Given this list of marker genes GPRC5C, NMI (N-myc and STAT interactor), RRM2, IRF7, NECTIN2, PTH1R, SLURP1, CXCL9, ESRRG, ACOT9, CFB, TYMS, EZH2, TRAFD1, SERPINE1, KCNJ14, CCR8 (NCBI Gene Id 1237), PCBP3 (NCBI Gene Id 54039), TNNT1, GABBR2, CCL3, BIRC5, ETV7, CBR1, AVPR1A, APOL1, IFITM3, H2AC18, JAK2 (Janus kinase 2), CHST8, CACNA1A, CD19, RBCK1, CCL7, IFNA6, GUCY1A2, CKS2, POLR3D, UBE2C, GRM7, LAMP5, HSPB1, BCL2L14, MT1X, TRIM21, ZBTB32, FAS, VCAM1, LYPD1, MMP25, SEPTIN4, MMP14, IL36A, HESX1, DYNLT1 (NCBI Gene Id 6993), IFIT3, APOL3, FST, GINS2, AURKB, CDC45, IL15, VAMP5, BATF3, AURKA, PLSCR1, MT2A, FHL2, IL9, XAF1, IFITM2, IDO1, CCL17, TRAF2, FA2H, INSM1, IGFALS, CHST3, PTGER3, NFE2L3, PARP11, RNASEL (NCBI Gene Id 6041), SRC, ADGRE5, VRK2, PLAC1, IGFBP1, MMP9, PML, IRF1, IFI6, NAMPT, OAS2, EIF2AK2, CLEC11A, RELB, IFI44L, IFIH1, KCNK5, AR, ESPL1, SP140, SIGLEC1, HSPBP1, GCH1, PSMB9, LIMK2, LAMP3, OAS1, MUC1, IFITM1, C1QA, SLCO4A1, FGL2, SLC6A12, SOCS2, PROCR, CD38 (CD38 molecule), MNDA, G0S2, IFI44, MX2, CXCL10, IL6, GMPR, SERPING1, FPR2, BMAL2, MYRF, GGT5, APBA1, LMO2, KIF13A, PARP3, SCNN1G, INHBA, ISG20, P2RY13, CLDN7, ZWINT, FSHB, CXCL1, LGALS3BP, PHLDA2, MAFF, TNFAIP6, AXL, KIFC3, CYP27B1, CXCL11, SIK1, SPHK1, MT1H, TK1, IFIT5, APOL6, MAP3K7CL, BST2, TFEC, ENPP2, APOBEC3B, ENTREP3, GDF11, FFAR2, H1-0, CCND1, TPX2, UBE2S, CCL13, USP18, MX1, EBI3, HERC5, GZMB, CCL2, C1S, ZBP1, ISG15, OASL, NR0B1, HCAR3, C1RL, ATF5, SEMA4A, GBP1, RTP4, IFIT1, SLC4A2, CD72, CCL8, MXD1, CDKN1A, NRG1, HSD11B1, GPALPP1, FCGR1A, CCL19, SOCS1, LAMB3, EGR2, SPAG1, BMPR1B, LY6E (NCBI Gene Id 7999), SLC31A2, RIGI, C2, PTGIR, TYMP, IGF2BP3, HMMR (hyaluronan mediated motility receptor), L1CAM, RGS1, DUSP6, CLEC4A, ALAS1, PRRG4, PSMA2, CCL18, GRID2, BAZ1A, CCNA2 (cyclin A2), PBK, ADAMDEC1, IFNG, IL3RA, JUP, UBE2L6, CLCNKA, LIF, DUSP5, MYOF, KCNJ2, VPREB3, H6PD, CHST12, PHF11, TRAF4, HLX, HOXC5, PSME2, WARS1, SP110, FSCN1, PAK6, NCAPG, OAS3, CSF2RB, LAP3, SCO2, F3, TAP2, IFI27, IL15RA, TNFSF10 (TNF superfamily member 10), TMEM176A, SLC2A6, LAG3, here is a description of the gene set: Human Gene Set: GARCIA_PINERES_PBMC_HPV_16_L1_VLP_AGE_18_25YO_STIMULATED_VS_UNSTIMULATED_0DY_VACCINATION_INDEPENDENT_UP studied in species Homo sapiens Genes up-regulated in peripheral blood mononuclear cell stimulated vs unstimulated in young adults (18-25) after exposure to HPV-16 L1 VLP, time point 0D. Comment: List of Genes induced by VLP directly, independently of vaccination (p<0.05 and FC>1.30) from publication García-Piñeres AJ, Hildesheim A, Dodd L, Kemp TJ, Yang J, Fullmer B, Harro C, Lowy DR, Lempicki RA, Pinto LA (PMID 19155521) Human papillomavirus (HPV) virus-like particle (VLP) vaccines were recently licensed. Although neutralizing Ab titers are thought to be the main effectors of protection against infection, early predictors of long-term efficacy are not yet defined and a comprehensive understanding of innate and adaptive immune responses to vaccination is still lacking. Here, microarrays were used to compare the gene expression signature in HPV-16 L1 VLP-stimulated PBMCs from 17 vaccine and 4 placebo recipients before vaccination and 1 mo after receiving the second immunization. Vaccination with a monovalent HPV-16 L1 VLP vaccine was associated with modulation of genes involved in the inflammatory/defense response, cytokine, IFN, and cell cycle pathways in VLP-stimulated PBMCs. Additionally, there was up-regulation of probesets associated with cytotoxic (GZMB, TNFSF10) and regulatory (INDO, CTLA4) activities. The strongest correlations with neutralizing Ab titers were found for cyclin D2 (CCND2) and galectin (LGALS2). Twenty-two differentially expressed probesets were selected for confirmation by RT-PCR in an independent sample set. Agreement with microarray data was seen for more than two-thirds of these probesets. Up-regulation of immune/defense response genes by HPV-16 L1 VLP, in particular, IFN-induced genes, was observed in PBMCs collected before vaccination, with many of these genes being further induced following vaccination. In conclusion, we identified important innate and adaptive response-related genes induced by vaccination with HPV-16 L1 VLP. Further studies are needed to identify gene expression signatures of immunogenicity and long-term protection with potential utility in prediction of long-term HPV vaccination outcomes in clinical trials.